The following is a description of a gene set: part of: L1CAM interactions Neurofascin is an L1 family immunoglobulin cell adhesion molecule involved in axon subcellular targeting and synapse formation during neural development. There are a range of different isoforms identified in Neurofascin of which two of them are well studied the 186kDa commonly referred to as neuronal form and is present in node of Ranvier neurons and the 155kDa form known as a glial form present in schwann cells.<br>Neurofascin colocalizes with NrCAM and ankyrinG at the nodes of Ranvier. Neurofascin participates in transheterophilic adhesion with NrCAM and stimulates neurite outgrowth in chicken tectal neurons. The last few amino acids of neurofascin form the PDZ class I binding motif (SLA) and through these last few amino acids it associates with syntenin-1. species: Homo sapiens Reactome Pathway: Neurofascin interactions, and this is the list of marker genes: CNTNAP1, NFASC, SDCBP, DCX, ANK1, CNTN1, NRCAM